The following is a description of a gene set: The directed movement of proline, pyrrolidine-2-carboxylic acid, into, out of or within a cell, or between cells, by means of some agent such as a transporter or pore. studied in species Mus musculus Mouse Gene Set: GOBP_PROLINE_TRANSPORT, and this is the list of marker genes: Slc7a5, Slc6a20b, Slc36a4, Slc6a20a, Ace2, Slc6a17 (NCBI Gene Id 99905), Cltrn, Slc38a2, Slc6a7, Slc6a15, Slc3a2, Slc36a1, Slc36a2, Slc1a4